The following is a description of a gene set: The chemical reactions and pathways involving the nucleotide cAMP (cyclic AMP, adenosine 3',5'-cyclophosphate). Mouse Gene Set: GOBP_CAMP_METABOLIC_PROCESS studied in species Mus musculus, and this is the list of marker genes: Adcy10, Epha2, Adcy2, Pde7a, Pde4a, Pde8a, Pde8b, Adcy6, Adcy9 (adenylate cyclase 9), Pde4c, Pth2, Adcy5, Adcy3, Pde7b, Pde4d, Adcy4, Pde10a, Adcy8, Hrh3, Adcy7, Adcy1, Cacnb4